The following is a description of a gene set: species: Homo sapiens Human Gene Set: GOMF_NETRIN_RECEPTOR_ACTIVITY Combining with a netrin signal and transmitting the signal from one side of the membrane to the other to initiate a change in cell activity., and this is the list of marker genes: UNC5D, UNC5C (NCBI Gene Id 8633), UNC5A, UNC5B, UNC5CL